The following is a description of a gene set: Recycling of bile acids and salts Human Gene Set: REACTOME_RECYCLING_OF_BILE_ACIDS_AND_SALTS studied in species Homo sapiens, and this is the list of marker genes: SLC10A1, SLC51B, NCOA1, RXRA, SLC51A, SLC10A2, SLCO1A2, NCOA2, NR1H4, SLCO1B3, SLC27A5, BAAT (NCBI Gene Id 570), ABCB11, ABCC3, FABP6, ALB, SLCO1B1, STARD5